Given this list of marker genes TNF, SNAI1, NFKB1, GFI1, IFNG, SNAI2, here is a description of the gene set: Human Gene Set: GOBP_REGULATION_OF_VITAMIN_D_BIOSYNTHETIC_PROCESS Any process that modulates the rate frequency or extent of a vitamin D biosynthetic process. Vitamin D biosynthesis is the chemical reactions and pathways resulting in the formation of vitamin D, any of a group of related, fat-soluble compounds that are derived from delta-5,7 steroids and play a central role in calcium metabolism. Specific forms of vitamin D include calciferol (ergocalciferol; vitamin D2) and cholecalciferol (calciol; vitamin D3). studied in species Homo sapiens